The following is a description of a gene set: Mouse Gene Set: GOBP_NEURON_CELL_CELL_ADHESION species: Mus musculus The attachment of a neuron to another cell via adhesion molecules., and this is the list of marker genes: Nlgn1, Nrxn1, Astn1, Nlgn2 (NCBI Gene Id 216856), Nlgn3, Ret, Astn2, Tnr, Cdk5r1